The following is a description of a gene set: Mouse Gene Set: REACTOME_MITOCHONDRIAL_UNCOUPLING Mitochondrial Uncoupling studied in species Mus musculus, and this is the list of marker genes: Ucp2, Ucp3, Pm20d1, Slc25a4, Ucp1, Slc25a14, Slc25a27